Given this list of marker genes Ndc1, Chtop, Nup35, Poldip3, Rae1 (NCBI Gene Id 66679), Nup107, Rbm8a, Ncbp2, Thoc7, Pom121, Aaas, Nup62, Nup205, Nup98, Casc3, Eif4a3, Nxt1 (NCBI Gene Id 80534), Magoh, Seh1l, Ranbp2, Eif4e, Srrm1, Nup155, Cpsf2, Nup88, Nup58, Cpsf1, Alyref, Nxf7, Sec13, Nxf1, Nup214, Zc3h11a, Nxf2, Ncbp1, Nup133, U2af1l4, Srsf9, Srsf2, Srsf1, Srsf3, Ddx39a, Thoc2, Fip1l1, Nup153, Slbp, Nup85, Nup50, Thoc1, Nup188, Nup37, Sarnp, Sympk, Fyttd1, Nup43, Nup210, U2af1, Srsf11, Thoc3, Dhx38, Tpr (translocated promoter region, nuclear basket protein), Srsf5 (serine and arginine-rich splicing factor 5), Thoc6, Nup93, Slu7, Nup42, Gle1, Rnps1, Ddx39b, Upf3b, Nup54, Cpsf3, U2af2, Cpsf4, Srsf7, Wdr33, Nup160, Cdc40, here is a description of the gene set: studied in species Mus musculus Mouse Gene Set: REACTOME_TRANSPORT_OF_MATURE_TRANSCRIPT_TO_CYTOPLASM Transport of Mature Transcript to Cytoplasm